Given this list of marker genes MSX1, NECTIN1, IRF6, TP63, NHS, here is a description of the gene set: The presence of a supernumerary, i.e., extra, maxillary incisor, either the primary maxillary incisor or the permanent maxillary incisor. studied in species Homo sapiens Supernumerary maxillary incisor Human Gene Set: HP_SUPERNUMERARY_MAXILLARY_INCISOR